The following is a description of a gene set: species: Mus musculus Mouse Gene Set: GOBP_NEGATIVE_REGULATION_OF_MEIOTIC_CHROMOSOME_SEPARATION Any process that stops, prevents or reduces the frequency, rate or extent of meiotic chromosome separation., and this is the list of marker genes: Knl1, Mos, Chfr, Ttk, Zwint (ZW10 interactor)